The following is a description of a gene set: Human Gene Set: GOBP_REGULATION_OF_RELAXATION_OF_MUSCLE species: Homo sapiens Any process that modulates the frequency, rate or extent of relaxation of muscle., and this is the list of marker genes: SRI, DCANP1, SLN, PDE4D, ABCC8 (NCBI Gene Id 6833), NEUROG1, HRC, PLN, CHGA, CAMK2D, TIFAB, ACTN3, PDE4B, GRK2